The following is a description of a gene set: from publication Zhan F, Huang Y, Colla S, Stewart JP, Hanamura I, Gupta S, Epstein J, Yaccoby S, Sawyer J, Burington B, Anaissie E, Hollmig K, Pineda-Roman M, Tricot G, van Rhee F, Walker R, Zangari M, Crowley J, Barlogie B, Shaughnessy JD Jr (PMID 16728703) Human Gene Set: ZHAN_MULTIPLE_MYELOMA_LB_UP To better define the molecular basis of multiple myeloma (MM), we performed unsupervised hierarchic clustering of mRNA expression profiles in CD138-enriched plasma cells from 414 newly diagnosed patients who went on to receive high-dose therapy and tandem stem cell transplants. Seven disease subtypes were validated that were strongly influenced by known genetic lesions, such as c-MAF- and MAFB-, CCND1- and CCND3-, and MMSET-activating translocations and hyperdiploidy. Indicative of the deregulation of common pathways by gene orthologs, common gene signatures were observed in cases with c-MAF and MAFB activation and CCND1 and CCND3 activation, the latter consisting of 2 subgroups, one characterized by expression of the early B-cell markers CD20 and PAX5. A low incidence of focal bone disease distinguished one and increased expression of proliferation-associated genes of another novel subgroup. Comprising varying fractions of each of the other 6 subgroups, the proliferation subgroup dominated at relapse, suggesting that this signature is linked to disease progression. Proliferation and MMSET-spike groups were characterized by significant overexpression of genes mapping to chromosome 1q, and both exhibited a poor prognosis relative to the other groups. A subset of cases with a predominating myeloid gene expression signature, excluded from the profiling analyses, had more favorable baseline characteristics and superior prognosis to those lacking this signature. Top 50 up-regulated genes in cluster LB of multiple myeloma samples belonging to the low bone disease group. species: Homo sapiens, and this is the list of marker genes: CACNB3, MAP4K3, BIK, COPZ2, PECAM1, IZUMO4, PLEKHA7, RELL1, MBD2, ARID5B, BOC, FLNB, C1orf226, PLS1, USP53, ARNT2, PLXNA1 (NCBI Gene Id 84202), MATCAP2, HRK, PHACTR3 (NCBI Gene Id 85418), EDN1, MAST4, ASXL2, CSF2RB, CGREF1, SLC39A6, CYBRD1, ADTRP, NTHL1, RASGRP1, LYPD6B, SRGAP2, SAMD3, PPP1R14A, HES5, PCGF5, ADAM22, SMAP2, KCNJ11, P2RX5, CFLAR, SCUBE1, COL9A2, NAMPT, ITGB1, LINC01088, PARP15